The following is a description of a gene set: studied in species Homo sapiens Abnormality of the tonsils An abnormality of the tonsils. Human Gene Set: HP_ABNORMALITY_OF_THE_TONSILS, and this is the list of marker genes: BTK, CA2, JMJD1C, IDS, MPEG1, ELANE, DCLRE1C, UFD1, IDUA, HIRA, IL2RG, ARVCF, ADA, CYBC1 (NCBI Gene Id 79415), SEC61A1, SCNN1G, SCNN1A, RIPK1, PIK3CD, RSPRY1, C3, TBX1, COMT, RREB1, ABCA1, PIK3R1, TBK1, IL2RA, CD40LG, IGHG2, BLM, ZBTB7A, GP1BB, PTEN, SEC24C, AKT2, SCNN1B, MYO5A, IGKC